The following is a description of a gene set: Human Gene Set: GSE17721_CPG_VS_GARDIQUIMOD_24H_BMDC_DN Genes down-regulated in comparison of dendritic cells (DC) stimulated with CpG DNA (TLR9 agonist) at 24 h versus DC cells stimulated with Gardiquimod (TLR7 agonist) at 24 h. species: Homo sapiens mouse primary BMDCs were stimulated with tlr ligands and gene expression changes were profiled on Affymetrix arrays from publication Amit I, Garber M, Chevrier N, Leite AP, Donner Y, Eisenhaure T, Guttman M, Grenier JK, Li W, Zuk O, Schubert LA, Birditt B, Shay T, Goren A, Zhang X, Smith Z, Deering R, McDonald RC, Cabili M, Bernstein BE, Rinn JL, Meissner A, Root DE, Hacohen N, Regev A (PMID 19729616), and this is the list of marker genes: MAPK11, GAS2, POLR1B, MMP2, PHPT1, TMOD2, PRXL2A, ARCN1, CYBB, MTF2, AK3, CMYA5, KCNE5, SLC18A1, CCN2, ZMPSTE24, TMEM243, QSER1, RNF149, ADORA2B, PON3, RAC1, NCR1, GINM1, EIF2B1, N4BP3, ADSL, ADH5, PIK3C2A, PTGR1, CCDC34, GPR155 (NCBI Gene Id 151556), TFB2M, TTI1, CD14, CHMP4B, PLGRKT, FKBP2, PKD2, TBCC, RGS2, CENPQ, JPH2, CFP, CALCOCO2 (NCBI Gene Id 10241), SCML2, MPP1, GPR45, RPP14, COX16, TPT1, FAM8A1, KITLG, AP3M1, ZCCHC3, MYCL, SERPINI1, LRRK2, OSTC, INMT, AXL, TECR, PDE1B, FLNC, MMP9, NAE1, SPTLC1, TFPI, PPP1R14B, FNTA, DPYSL2, NSUN4, SGMS1, MYO1B, NFKBIZ, ITGA4, ZNF146, SLAIN1, NDFIP1, SOCS4, RP2, IQGAP2, GSDME, POLD4, WBP4, HMG20B, SPATS2, TRMT5, SERPINB2, DTWD1, CCDC120, THRSP, ACOT12, MED11 (NCBI Gene Id 400569), HDHD5, SELP, TMEM19, NSG1, RAD23B, APOC2, PPM1D, PLEKHB2, MFF, SNX4, CST11, CD52, DNM3, PGAM2, GUCY2C, NET1, CD300LD, TLE2 (TLE family member 2, transcriptional corepressor), CLCN1, IL1RAP, AIFM1, MICOS13, PTGER1, S100A9, PLEKHG2, TMED7 (NCBI Gene Id 51014), SNTG1, VSIG2, MDM1, RTP4, OPRK1, KLHDC8A, NUCB2, ALDH18A1, CLMN, FAM76B, GOLIM4, DNAJC3, KLK4, NPNT, DRC3, DEPDC1, NOMO1, UBAC2, RAP1A, CD83, SLPI, TCF21, SFRP1 (secreted frizzled related protein 1), DACH1, SEC11A, RNF103, CFAP97, APLF, IL18RAP, TPD52L2, MYO1E, NTAN1, PCNX3, SEZ6L2, HABP2, CLINT1, CERS5, MIGA2, CLCN7, CDC16, SMAD3, SMN1, CUTC, SPIRE2, TSPAN13, DAD1, C1QL3, RAB4B, FMNL3, LHX5, UBA3, BEX2, TM9SF2, TNK2, TXN, MRAS, AOPEP, ICAM4, ATXN1, TMEM263, SNAP23, NEDD8, TSPAN4, C21orf91, FAM162A, IL1RL2, NSG2, PARD6A, SH2B3 (NCBI Gene Id 10019), ERGIC2, CSF2RA, LYVE1, SLC31A1, FGF18, B3GNT5, RWDD3, PHOSPHO2, TMEM186, ABCD2, CNOT2